Given this list of marker genes TRAF1, IER2, ITGB2, GOSR1, EFTUD2, JARID2, ASRGL1, DIAPH1, BZW2, NABP1, DDX47, COPG1, HM13, TNFSF11, MYO6, PRKCQ, EIF2B2, ACTN2, LCK, ADAM22, CHCHD7, PXN, GIMAP4, FRMD6, PPP4C, DOK2, CNGA1, ROM1, HPN, WAS, PSMB8, TNK2, ITM2C, PITPNM1, SLC3A2, HLA-A, PRKACB, DAD1, SUDS3, SRGAP2, BUB3, CSNK1G2, FAM117A, RHOG, LEMD2, B4GALNT1, NLK, F2R, CD247, TRIR, ARHGAP9, STIM1, DECR1, FADS1, ADGRG3 (adhesion G protein-coupled receptor G3), METTL9, UQCRC1, AKAP8L, KLRG1, SEPTIN9, CD27, PHF23, NBEAL2, PELI1, FRAT1, RPS6KA4, COPS3, LONP1, RASL11B, IFIT3, CORO1B, RNASE4, FLII, PRF1, SIT1, TNFRSF18, AUP1, DYNLL2, SMPD1, PFKP (NCBI Gene Id 5214), IFITM10, GLIPR2, PER1, CD5, SUN2, PSMD9, VAV1, DNAJC1, PRPF31, CRYBG1, NCBP1, ABHD8, TAP1, IQGAP2, BRK1, SMPDL3A (sphingomyelin phosphodiesterase acid like 3A), PCID2, FYN (FYN proto-oncogene, Src family tyrosine kinase), GPC1, BCAP31, PSMB3, EIF2B4, RAC2, RIN2, CSTF2T, NPEPL1, REPS1, ISG15, CD3G, CTSD, IDNK, DAP, CD82, PEX5, CAD, EIF4A3, TMEM179B, CCR9, SH2D2A, PMM2, SOAT2, E4F1, NDN, ABCF1, SLC38A10, TMEM9B, ATP6V1E1 (NCBI Gene Id 529), CXCL10, MRPS12, SEPHS2, VMP1, RAD50, GZMA, STX6, SDHAF1, VCAM1, PSME1, CTSV, RASSF5, GBA1, TSPAN32, RPL19, ACAT2, FBXW4, PPP5C, PGLYRP1, PTGER4, PFDN2, MAPKAPK2, PARP8, STARD3, EVL, MED10, SPNS1, SFMBT2, CCL5, NMB, CLCN4, FIP1L1 (factor interacting with PAPOLA and CPSF1), CD3E, EYA2, SLC39A8, PSMB9, TCF7, NUP50, CKB, PHPT1, BCL6, PKP4, P2RX7, LAPTM5, RGS3, MTHFD2, CD28, CISH (cytokine inducible SH2 containing protein), ALOX15B, DENND4C, MED28, THY1, IFNAR2, DGAT1, SATB1, PSME3IP1, WRN, NFKBIA, FAS, BOP1, IFIT2, HLA-E, DUSP11, RAMP1, KLRD1, IL18RAP, PSMC3, HACD3, KLK8, EIF2D (eukaryotic translation initiation factor 2D), RFLNB, IFIH1, CNDP2 (carnosine dipeptidase 2), here is a description of the gene set: We used microarrays to compare gene expression between healthy human CD161++CD8aa and CD161++CD8ab T cells. species: Homo sapiens Genes down-regulated in KLRB1 high T cells: CD8A versus CD8A CD8B. Human Gene Set: GSE33374_CD8_ALPHAALPHA_VS_ALPHABETA_CD161_HIGH_TCELL_DN from publication Walker LJ, Kang YH, Smith MO, Tharmalingham H, Ramamurthy N, Fleming VM, Sahgal N, Leslie A, Oo Y, Geremia A, Scriba TJ, Hanekom WA, Lauer GM, Lantz O, Adams DH, Powrie F, Barnes E, Klenerman P (PMID 22086415)